The following is a description of a gene set: Genes up-regulated in monocytes isolated from peripheral blood samples of patients with mucosis fungoides compared to those from normal healthy donors. PURPOSE: Increased production of Th2 cytokines characterizes Sezary syndrome, the leukemic form of cutaneous T-cell lymphomas (CTCL). To identify the molecular background and to study whether shared by the most common CTCL subtype, mycosis fungoides, we analyzed the gene expression profiles in both subtypes. EXPERIMENTAL DESIGN: Freshly isolated cells from 30 samples, representing skin, blood, and enriched CD4(+) cell populations of mycosis fungoides and Sezary syndrome, were analyzed with Affymetrix (Santa Clara, CA) oligonucleotide microarrays, quantitative PCR, or immunohistochemistry. The gene expression profiles were combined with findings of comparative genomic hybridization of the same samples to identify chromosomal changes affecting the aberrant gene expression. RESULTS: We identified a set of Th1-specific genes to be down-regulated in Sezary syndrome as well as in a proportion of mycosis fungoides samples. In both Sezary syndrome and mycosis fungoides blood samples, the S100P and LIR9 gene expression was up-regulated. In lesional skin, IL7R and CD52 were up-regulated. Integration of comparative genomic hybridization and transcriptomic data identified chromosome arms 1q, 3p, 3q, 4q, 12q, 16p, and 16q as likely targets for new CTCL-associated gene aberrations. CONCLUSIONS: Our findings revealed several new genes involved in CTCL pathogenesis and potential therapeutic targets. Down-regulation of a set of genes involved in Th1 polarization, including the major Th1-polarizing factor, TBX21, was for the first time associated with CTCL. In addition, a plausible explanation for the proliferative response of CTCL cells to locally produced interleukin-7 was revealed. from publication Hahtola S, Tuomela S, Elo L, Häkkinen T, Karenko L, Nedoszytko B, Heikkilä H, Saarialho-Kere U, Roszkiewicz J, Aittokallio T, Lahesmaa R, Ranki A (PMID 16914566) species: Homo sapiens Human Gene Set: HAHTOLA_MYCOSIS_FUNGOIDES_UP, and this is the list of marker genes: HBD, CA2, EMC3, MMP9, TOP1, LILRA5, SIK3, SOD2, TMEM140, H2BC12, H2AC18, H3C10, STAT1, SEC14L1, SNCA, S100P, TSC22D1, G0S2, H2BC21